Given this list of marker genes PYGB, PYGL, GYS1, PPP2R5A, HK2, CALM1, PHKG1, GSK3B, PPP2R5D, HK3, GYG2, GSK3A, PPP2R5C, HKDC1, PPP2R5E, PPP2R3A, PYGM, GYG1, PTPA, PHKB (NCBI Gene Id 5257), PPP2R1A, AGL, HK1, PHKG2, GBE1, PHKA2, PHKA1, PPP2R2C, GYS2, PPP2R5B, CALM3, PPP2R1B, UGP2, PPP2R2B, PPP2R2A, PGM1, PPP2CB, PPP2CA, CALM2, PPP2R3B, here is a description of the gene set: Human Gene Set: WP_GLYCOGEN_SYNTHESIS_AND_DEGRADATION studied in species Homo sapiens Glycogen synthesis and degradation